The following is a description of a gene set: This event has been computationally inferred from an event that has been demonstrated in another species.<p>The inference is based on the homology mapping from PANTHER. Briefly, reactions for which all involved PhysicalEntities (in input, output and catalyst) have a mapped orthologue/paralogue (for complexes at least 75% of components must have a mapping) are inferred to the other species. electronically inferred by orthology from the curated human pathway Reactome Pathway: Beta oxidation of octanoyl-CoA to hexanoyl-CoA part of: mitochondrial fatty acid beta-oxidation of saturated fatty acids species: Mus musculus, and this is the list of marker genes: Hadha